Given this list of marker genes CCDC47, TMCO1, SGTB, NCLN, RAB5IF, NOMO3, UBL4A, TMEM147, SGTA (small glutamine rich tetratricopeptide repeat co-chaperone alpha), GET4, NOMO1, BAG6, NOMO2, WDR83OS, here is a description of the gene set: Human Gene Set: GOCC_ER_MEMBRANE_INSERTION_COMPLEX A protein complex that is involved in the post-translational delivery of tail-anchored (TA) membrane proteins to the endoplasmic reticulum. TA membrane proteins, also called type II transmembrane proteins, contain a single C-terminal transmembrane region. Some ER membrane insertion complex subunits are conserved between different species such as mammals and budding yeast. species: Homo sapiens